Given this list of marker genes MMP11, TNFSF11, MEST, TRPA1, RBP1, FABP5, IL7R, TMEM176B, F2RL2, TGM2, CXCL14, CST1, BMP5, TSLP, PDPN, PPP1R14A, PLAU, WNT5A, BMP4, GDF15, SOX6, GMFG, F2R, TGFBI, TMEM176A, IGFBP2, CXCR4, PDGFRA, COL12A1 (NCBI Gene Id 1304), PRDM1, MGLL, PDGFD, TM4SF1, DMKN, ETS2, MME (membrane metalloendopeptidase), PLAT, GJA1, AGT, F3, HSD17B2, FENDRR, NSG1, EMID1, LSP1, PROCR, PAG1, TSPAN33, DLL1, SPRY1, here is a description of the gene set: species: Homo sapiens from publication Gavish A, Tyler M, Greenwald AC, Hoefflin R, Simkin D, Tschernichovsky R, Galili Darnell N, Somech E, Barbolin C, Antman T, Kovarsky D, Barrett T, Gonzalez Castro LN, Halder D, Chanoch-Myers R, Laffy J, Mints M, Wider A, Tal R, Spitzer A, Hara T, Raitses-Gurevich M, Stossel C, Golan T, Tirosh A, Suvà ML, Puram SV, Tirosh I (PMID 37258682) Genes upregulated in subsets of cells of a given type within various tumors In this study, an extensive analysis was conducted to define meta-programs (MPs) capturing intra-tumor heterogeneity across a spectrum of tumor types. The approach utilized non-negative matrix factorization (NMF) to analyze each cell type separately within individual tumor samples. This involved the analysis of malignant cells, macrophages, fibroblasts, endothelial cells, epithelial cells, T-cells, and B-cells. NMF was executed with varying parameter values (K=4, 5, 6, 7, 8, 9), thereby generating 39 programs for each cell type per sample. Each NMF program was summarized by the top genes based on NMF coefficients.\nRobust MPs were then delineated for each cell type using a set of stringent criteria, including recurrence within the same tumor, similarity to programs in other tumors, and non-redundancy within a tumor. Subsequently, these robust NMF programs were clustered (per cell type) based on Jaccard similarity, leading to the identification of MPs associated with each cell type.\nTo enhance the quality of the MPs, a refinement steps were undertaken, involving the removal of MPs suspected of reflecting low-quality data (with an overrepresentation of ribosomal proteins or mitochondrial-encoded genes), single-study inclusion, or similarity to miss-annotated cell types. Human Gene Set: GAVISH_3CA_METAPROGRAM_FIBROBLASTS_CAF_10